The following is a description of a gene set: Human Gene Set: TAL1BETAE47_01 Genes having at least one occurrence of the motif NNNAACAGATGKTNNN in the regions spanning 4 kb centered on their transcription starting sites. This matches the TAL1, TCF3 transcription factor binding site V$TAL1BETAE47_01 (v7.4 TRANSFAC). studied in species Homo sapiens, and this is the list of marker genes: NAA15, KIRREL2 (kirre like nephrin family adhesion molecule 2), PLXNA3, EHD4, PCDH12, FNDC3A, GIGYF2, TTN, ACY3, CEP41, PNMA1, DARS1, FOXP1, UBE2E4P, TRIM3, WNT9A, HRH3, BARHL2, PHEX, NEUROD2 (neuronal differentiation 2), GRID2, MED27, PROK2, TMEM59L, MEF2C, GLDN, TLK1, DCHS2, C1QA, ST3GAL2, ARHGEF38, MRPL58, ZNF485, CTDNEP1, SERPING1, ABCD2, RORB, SLC6A10P, RNF182, GABRA6, TMEM71, KRAS, FMNL3, KIF9, TFDP2, EYA3, PYY, ARHGAP44 (Rho GTPase activating protein 44), PLPP3, SLC18A3, KCNJ2, UPK2, GNAS (NCBI Gene Id 82944), HTR2C, WNT6, BRD4, INHBE, TJAP1, EPHB2, SWAP70, CHAT (choline O-acetyltransferase), BRME1, VWA5B1, HOXB6, GTF2A1L, NPR2, FHL3, TSPAN13, HCN4, S100A10 (S100 calcium binding protein A10), PDE1A, DLL4, SH3KBP1, HCK, SCGN, TFAP4, ABHD16A, WWC1, C17orf58, FGF7, POU4F1, R3HDM1, PRKN, CADM2, SRPX2, CD79B, BHLHE22, FGF9, TMEM131L, C1QTNF4, PIK3R1, RUNX1T1, PACRG, MOAP1, NXPH4, NABP2, PCDH1, ITGBL1, JADE1, GFRA3, LTBP1, TSKU, SEMA6D, PMF1, GTDC1, CLNK, HSD11B1, KIRREL3, MYCLP1, GNAI2 (G protein subunit alpha i2), ZBTB18 (NCBI Gene Id 10472), CLVS1, NAT14, HTR7, HNF1B, RIOK3, STK3, ARHGAP22, LAMTOR2, FOXB1, DMD, CELF1, SAP30L, ST6GALNAC5, CELA3B, KMT2E, ZFPM2, CPNE9, PLCB1, UBQLN4, SCN1B, ARL4A, APOBEC4, LRRN1, LLGL2, ELL2, SOBP, DCX, PI15, GPD1, NEB, KLF8, PHACTR3, GFRA1, SIM1, SELENOM, CBFA2T3, DTX2, SERTAD4, MARK1, HOXA7, CDC42EP4 (CDC42 effector protein 4), FAP, BANF2, SLC24A3, NR2F6, EPB41L4B, FOXP2, TRIM37, DDIT3, LEF1, OMG, GFI1, MAP7, SMAD3 (NCBI Gene Id 51521), LRRC8C, ELAVL4, CPNE1, STARD13, PRMT3, ARPC1A, CHST13, GABARAPL2, LINC03124, SULF1, AFF3, RCOR2 (REST corepressor 2), LIN28A, MBNL2, RTL9, SOX5, PYY2, OSM, ASB4, ANGPTL1, NDUFA4L2, NDP, FBRS, KLHL35 (kelch like family member 35), FGF10 (fibroblast growth factor 10), ATOH7, ELMO1, C7orf33, SMTN, TAFA1, ITGA8 (integrin subunit alpha 8), PRG4, GPX1 (NCBI Gene Id 2876), DAPK1, HRK, DDAH2, ELP5, KCNQ1DN, RNF19A, TCF12, FGD4, CHST9, ARSG, HAAO, EXOC6 (exocyst complex component 6), MYOCD, SCN5A, HSPB6, HOMEZ, DUSP10, NCKIPSD, PBXIP1, HECTD1, STAG1, TAC1, NHLH1, KERA, SEL1L, CDH23, MBD6, CDH6, NKD1, TMPRSS11F, KLHL18, BEX2, SIX6, TSPAN33, PHOX2B, PPP3CB, UBXN10, ACLY, KCNIP2, HOXA11, STAG2, CELA3A, GK, RBPJ, SMARCA1, RASL11B, RAG2, GPR173, LIMA1, TP63, ZNF516-DT, ZNF821, RCAN2, NPAS2, PHF21B, TP53INP2, PDLIM4